The following is a description of a gene set: Human Gene Set: GSE2770_TGFB_AND_IL4_ACT_VS_ACT_CD4_TCELL_2H_UP Th1 and Th2 cells arise from a common precursor cell in response to triggering through the TCR and cytokine receptors for IL-12 or IL-4. This leads to activation of complex signaling pathways, which are not known in detail. Disturbances in the balance between type 1 and type 2 responses can lead to certain immune-mediated diseases. Thus, it is important to understand how Th1 and Th2 cells are generated. To clarify the mechanisms as to how IL-12 and IL-4 induce Th1 and Th2 differentiation and how TGF-beta can inhibit this process, we have used oligonucleotide arrays to examine the early polarization of Th1 and Th2 cells in the presence and absence of TGF-beta after 0, 2, 6 and 48 hours of polarization. from publication Lund R, Aittokallio T, Nevalainen O, Lahesmaa R (PMID 14607935) studied in species Homo sapiens Genes up-regulated in CD4 T cells activated by anti-CD3 and anti-CD28: TGFB1 and IL4 (2h) versus untreated (2h)., and this is the list of marker genes: RPS10 (NCBI Gene Id 6204), SACS, GPAA1, PFDN5, RPL3, RPL35A, DPM3, TAF7, RPL13, RCN2, RPS3A, KRT10, FMR1, RPS10P5, CAMK1, KLK10, NAA16, RPS6, HOOK3, CXCL5, PSENEN (NCBI Gene Id 94939), COMMD6, CBX7, ITGAE, ABCC4, GCAT, BEX3, H3-3B, RPS8, PAK2, CFAP68 (NCBI Gene Id 737), SNRPN, RPS3, UGGT1, MPO, PAGR1, ESYT1, RNF144A, ATG2B, EEF1B2, FOXN3 (NCBI Gene Id 654111), CMPK1, ACADSB (NCBI Gene Id 654185), LTB, GALNT1, PNRC2, METTL9 (NCBI Gene Id 51108), UBE4B, PRXL2A, TBXAS1 (NCBI Gene Id 6916), UBA52, EIF3F, SPCS3, LPGAT1, MKKS, CUTA, RSC1A1, LRRC23, PABPC3, TLE2, MARK2P21, IL1A, PRR13, GPBP1, SCARF2, ATP6AP2, HLA-C, USP51, SVIP, SLC6A1, STX10, UQCRB, ILVBL, EDEM1, TMA7, ATRN, ITM2A, CRADD, RPL17, IMMP1L, SNRNP200 (small nuclear ribonucleoprotein U5 subunit 200), ATP1B1, FAAH2, TPCN1, DHX57, ADSS2, RPL7, IL13, KLF13, MSX1, ATP6V0E1, SNHG11, SLC10A4, RGP1, ERGIC3, PRDX2, ANAPC16 (NCBI Gene Id 119504), ARHGDIB, EIF4B, SMIM27, AKR7A3, TMEM256, IL26, CTPS2 (NCBI Gene Id 95807), GLTP (NCBI Gene Id 51228), NSMCE1, C1orf52, ARHGEF10, F3, AAK1, LYRM7, CCL22, HIPK2, CDHR3, SMAP1, FLACC1 (NCBI Gene Id 65070), DNAL1, SELENOS, HNRNPA0, TMPO-AS1, OIP5-AS1, ANKH, EIF3L, PABPC4, PIM3, RPL21, SDF4, ZNF410, TBL1XR1, EIF1B-AS1, TNFAIP8 (NCBI Gene Id 25816), PPP2R3C (protein phosphatase 2 regulatory subunit B''gamma), CHPT1 (choline phosphotransferase 1), IL1R1, TXNRD1, SLC35B4, SLC9A7, TOP2B, TNFSF15, POLDIP3, HLA-B, ACAA2, IER2, PITPNA-AS1, ARID5B, LORICRIN, SERF2, RAD52, MFSD14B, PARK7, SLC35D1, AGAP1, PABPC1, RPS17, RBL2, SIGLEC15 (NCBI Gene Id 284266), LTA4H, PRDX5 (peroxiredoxin 5), RUNX1, CERK, LAPTM4B, IGFBP6, KLF12 (NCBI Gene Id 82238), MRFAP1, CD3D, HACD2, OST4, BIVM, RPL27, DANCR, PRPF8, LDHAL6A, DAD1 (NCBI Gene Id 1603), CKLF, IL2RB, EPRS1, TMED10, CD164, FAM168B, PRKCA, NDUFA2, NDUFB1 (NCBI Gene Id 4707), PBX4, ATP13A3, STAT5B, PNN, CAV1, STRBP, SNHG9, ATXN1, COQ10B, RPS27A, RPL6, SELENOH, P4HTM, ZDHHC2, CCDC167